The following is a description of a gene set: studied in species Homo sapiens Human Gene Set: MIR4286 from publication Chen Y, Wang X (PMID 31504780) Genes predicted to be targets of miRBase v22 microRNA hsa-miR-4286 in miRDB v6.0 with MirTarget v4 prediction scores > 80 (high confidence targets)., and this is the list of marker genes: ZBTB1, PRDM11, ZPR1, TRAPPC2L, BEND3, DCP1A, ANKRD34A (ankyrin repeat domain 34A), CLDN11, FURIN, KCNA7, RBFOX1, VANGL1, CELF5, KLHDC3, MAGEA8, TMEM229B, NUS1, KIAA1671, MXI1, FAM120AOS, NPTX2, PLEKHA8, GLS2, FOXO4, GOLPH3, BTN3A2, RETREG3, RDH10, GANC, MAN2A2, DCTN5, ZBTB7B, WASHC4, NAA10, PTBP2, COL4A1, PPP4R3A, SLC10A7, UBE2R2, FBXW2, ZNF641, ZFP36L1, BCL11A, HMGA1, NDST1, TSHZ1, LRRC4, KCNC1, RNF144B, C3orf62, KCND1, PPIL1, FAM117B, CIRBP, PTGES3, PPM1E, CES3, MGAT3, RNF157, HSF5, MDK, ITPRID1, ADRA1A (NCBI Gene Id 148), C22orf46P (chromosome 22 open reading frame 46, pseudogene), LZTR1, G6PC2, ARHGEF38, IFFO2, TLN2 (talin 2), TMEM104, SEMA4F, FANCA, RNF34, SECISBP2L (SECIS binding protein 2 like), MEX3A, LIN28A, CRAMP1, GALNT1 (NCBI Gene Id 2589), GPR55, LDLR, IGLON5 (NCBI Gene Id 402665), NSD1, GABRA3, RORB, ZNF470, PHF1, BTN2A1, KHDC4, FBLIM1 (filamin binding LIM protein 1), SYT2, PPP4R1, ORMDL3